Given this list of marker genes OXCT2, SUGCT, ACAA1, ACSM3, OXCT1, here is a description of the gene set: Human Gene Set: GOMF_COA_TRANSFERASE_ACTIVITY studied in species Homo sapiens Catalysis of the transfer of a coenzyme A (CoA) group from one compound (donor) to another (acceptor).